The following is a description of a gene set: species: Homo sapiens Aplasia/Hypoplasia of the phalanges of the toes Human Gene Set: HP_APLASIA_HYPOPLASIA_OF_THE_PHALANGES_OF_THE_TOES, and this is the list of marker genes: WLS, BMPR1B, ARID1B, KCNN3, ATP6V1B2, RIPK4, GPC4, WNT7A, PTHLH, NOG, IHH, FIG4, LMNA, RAB23, TRPV4, PIGF, VAC14, EOGT, TBX5, TP63, ERF, MAP3K20, PIGL, TBC1D24, GDF5, ACVR1 (activin A receptor type 1), KCNH1, SMARCA4, HOXD13 (homeobox D13), ROR2, ARSL